The following is a description of a gene set: species: Homo sapiens from publication Jiang Y, Zhang W, Kondo K, Klco JM, St  Martin TB, Dufault MR, Madden SL, Kaelin WG Jr, Nacht M (PMID 12692265) Genes up-regulated in 786-0 cells (renal carcinoma, RCC) by the loss of VHL and in response to hypoxia. The von Hippel-Lindau tumor suppressor, pVHL, is a key player in one of the best characterized hypoxia signaling pathways, the VHL-hypoxia-inducible factor (VHL-HIF) pathway. To better understand the role of VHL in the hypoxia signaling pathways of tumor cells, we used serial analysis of gene expression (SAGE) to investigate hypoxia-regulated gene expression in renal carcinoma cells (786-0), with and without VHL. The gene expression profiles of the cancer cells were compared to SAGE profiles from normal renal proximal tubule cells grown under both normoxia and hypoxia. The data suggest that the role of VHL as a tumor suppressor may be more complex than previously thought. Further, the data reveal that renal carcinoma cells have evolved an alternative hypoxia signaling pathway(s) compared with normal renal cells. These alternative hypoxia pathways demonstrate VHL-dependent and VHL-independent regulation. The genes involved in such pathways include those with potential importance in the physiological and pathological regulation of tumor growth and angiogenesis. Some of the genes identified as showing overexpression in the cancer cells, particularly those encoding secreted or membrane-bound proteins, could be potential biomarkers for tumors or targets for rational therapeutics that are dependent on VHL status. Human Gene Set: JIANG_HYPOXIA_VIA_VHL, and this is the list of marker genes: GMFB, AIMP1, SLC3A2, SCARB2, RAB14, DGCR6L, LSM3, ENO2 (NCBI Gene Id 2026), UACA, TCEAL9, PPP2R5D, MRPS6, TRAPPC2L, RPLP0, PECR, TES, POLD1, SPATS2L, EWSR1